Given this list of marker genes MIR23AHG, BEST3, TRIB3, H4C8, RNU4ATAC, LINC02709, BCAN-AS2, POLDIP3, KMT2A (NCBI Gene Id 79951), STX16, SRI, H2BC17, WWTR1, EEPD1, H2AC8, WDR74, S100A2, SCAT8, NNMT, MYL12A, DLGAP1-AS2, RNU4-1 (RNA, U4 small nuclear 1), NAV3, LINC02288, STAT1, GLUD1P3, S100A16, RNU11, DUSP6 (NCBI Gene Id 1848), IER3-AS1, PRAC2, H4C2, BMS1P4, RNU6-1106P, FERMT2, ITGB1-DT, ANAPC5, RNU12, RNU5F-1, ABCA10, MED24, CXCL8, MALAT1, CLDN6 (claudin 6), GPX1, SSTR5-AS1, H2AC17, LY6K, LTBP1, AXL, CUL3, BMS1P4-AGAP5, STX1A, NAALADL2, AK5, ERCC1, LINC02989, RPS7, CYP1B1 (NCBI Gene Id 1545), KRT8, PVT1, GRAMD1B, VMP1, C1orf105, C12orf57 (chromosome 12 open reading frame 57), MIR27A, H2BC8, RNU5A-1, LINC01730, SH3TC2-DT, ENSG00000259617, HMGA2, H3-3B, H3C12, SMAD3, ENSG00000225676, TSPAN4, RNU7-1, CP, UBC, TMEM105, EYS, MSMP, LINC00513, EHD1, TRIB1, CD151, FLOT1, COX16, BHLHE40, LINC02970, MITD1, MIR5188, STX16-NPEPL1, LINC00649, HOXA10, H1-4, MYEOV, MIR584, SPRED2, ENSG00000266088, MRPL30, CLASP1, FEZ2, NEAT1, DDIT4, ROCK2, IGF2BP2-AS1, HDX, H4C11, KRT7, TTC3, MIR100HG, LINC02098, CLDN14, LINC02320, H3C4, SIGLEC15, SSTR5, ITGB1, ETS1, H4C3, PLAU, NRP1, RNU5E-1, RNU5E-4P, KRT18, LINC00511, RNA5SP146, LURAP1L-AS1, BRWD1 (bromodomain and WD repeat domain containing 1), PIGC, ITGB5, LINC02889, KRT15, MIR23A, RNU5B-1, ITGB2, RNU5D-1, TBL1X, RNU2-2P, here is a description of the gene set: studied in species Homo sapiens from publication Yevshin I, Sharipov R, Kolmykov S, Kondrakhin Y, Kolpakov F (PMID 30445619) Genes containing one or more binding sites for (MED25) in their promoter regions (TSS -1000,+100 bp) as identified by GTRD version 20.06 ChIP-seq harmonization. Human Gene Set: MED25_TARGET_GENES